Given this list of marker genes PLEKHA8, PLTP, CERT1, SPNS2, ATP10A, ABCA1, GLTP, ATP10D, PLEKHA8P1, ABCC1, ABCA2, CPTP, MTTP, MFSD2B, GLTPD2, TMEM63B (transmembrane protein 63B), PITPNB, ABCB4, ABCG2, ABCB1, ATP10B, here is a description of the gene set: Human Gene Set: GOMF_SPHINGOLIPID_TRANSPORTER_ACTIVITY studied in species Homo sapiens Enables the directed movement of sphingolipids into, out of or within a cell, or between cells. Sphingolipids are a class of lipids containing the long-chain amine diol sphingosine or a closely related base (a sphingoid).